Given this list of marker genes Pnp2, Slc29a3, Nme2, Ada, Pnp, Nt5c2, Nme1, here is a description of the gene set: electronically inferred by orthology from the curated human pathway Reactome Pathway: Ribavirin ADME species: Mus musculus part of: Drug ADME This event has been computationally inferred from an event that has been demonstrated in another species.<p>The inference is based on the homology mapping from PANTHER. Briefly, reactions for which all involved PhysicalEntities (in input, output and catalyst) have a mapped orthologue/paralogue (for complexes at least 75% of components must have a mapping) are inferred to the other species.